The following is a description of a gene set: Human Gene Set: HP_EXOCRINE_PANCREATIC_INSUFFICIENCY species: Homo sapiens Exocrine pancreatic insufficiency Impaired function of the exocrine pancreas associated with a reduced ability to digest foods because of lack of digestive enzymes., and this is the list of marker genes: PDX1, GCK (glucokinase), RABL3, PALB2, KRAS, PTF1A, TRMT5, BRCA2, GSTM3, EDNRA, DNAJC21, PUF60, PAX4, YARS1, BRCA1, STX1A, CLCA4, NEUROD1, INS, SLC26A9, MIF, SMAD4, HMOX1, KCNJ11 (NCBI Gene Id 3767), FCGR2A, GCLC, EFL1, PTRH2, TP53, HFE, TGFB1, ABCC8, PRSS2, SBDS, PRIM1, KCNN4, CEACAM6, PRSS1, PALLD, ATP6AP1, CDKN2A, CNOT1, SLC6A14, HNF4A, CEL, OFD1, SLC9A3, MADD, CTRC, ARX, HNF1B, FOCAD, COX4I2, CFTR, BLK, EIF2AK3, SERPINA1, GATA6, CCDC47, STAT3, HNF1A, SLC11A1, SPINK1, DCTN4, CEACAM3, JAG1, CTNS, UBR1, APPL1, NSD2, KLF11, SRP54